The following is a description of a gene set: Human Gene Set: HP_PUBERTY_AND_GONADAL_DISORDERS species: Homo sapiens Puberty and gonadal disorders, and this is the list of marker genes: PHKG2, EIF2S3, PIGQ, POLR3GL, FLI1, ZNF365, FOXA2, PTCH1, HROB, NTN1, HLA-DQB1, SOX10, GLI3, ATRX, TAF4, STUB1, ALDOA, TBL2, FAT4, OTX2, HSPG2, SLC12A5, LHX4, DISP1, ANTXR1, GJB2, MT-ATP8 (NCBI Gene Id 4509), POF1B (NCBI Gene Id 79983), NONO, CDKN1C, POR, LPIN2, ERCC5, HESX1, GTF2IRD2, OCA2, MAD2L2, EP300, CUL4B, TXNRD2, FGF8, AGPAT2 (NCBI Gene Id 681), TGIF1, PREPL, TP53, CEP290, ATP5F1D, DUSP6 (NCBI Gene Id 1848), STAT1, NUP107, KCNT1, COL25A1, TONSL, CAMKMT, TMEM270, TSC1, PWAR1, HJV, MYT1L, DNAJC30, PDGFB, IFT74, CREBBP, SMARCE1, TGFB1, BNC1, YARS2, HBB, SNORD115-1, ROBO1, BBIP1, CNTNAP2, POLR3B, FEZF1, TFR2, SNORD116-1, MRPS22, SRCAP, PNKP, CAV1, TRAF7, ALMS1, KDM6A (lysine demethylase 6A), SCARB2, HAMP, BAZ1B, CYP17A1, USP9X, MT-TS2, PIGP, CBX2, TUBA1A, GPR101, LRP5, NFIX, GBA1, GNRHR, OPA1, TNFSF4, FKBP6, FMR1, STIL, LIG3, ZMPSTE24, TNRC6B, PPM1B, BRIP1, HS6ST1, BTK, ATPAF2, GLI2, REV3L, FSHB (follicle stimulating hormone subunit beta), GRB10, DLK1, SAMD9, NIPBL, BBS4, SMAD4, CDON, LAS1L, CFAP418, PIK3CA, STS, SCAPER, ZEB2, NEUROD2, NPHP1, XPA, EIF2B1, LSS, MMP2, PPP1R15B, SNRPN, CCDC141, SLC32A1, POLD1, DYRK1A, FANCC, SGPL1, PRKAR1A, WDPCP, POLR3K, FGD1, MAP2K1, ATP5MK, CEP19, TBC1D24, RAB18, MC2R, PEX6, SLC12A3, MKS1, SEMA3A, SRA1, LEP, SRY, VPS13B, UBE2T, NHLH2, SCN1A, DDB2, BRCA1, CASZ1, RERE, GNAS, SMO, ATP5F1A, LGR4, MT-TQ, MT-TL1, PRDM13, UBE4B, BMP4, ERCC6, FGFRL1, PHKA2, STAR, TRIP4, NNT, IL17RD, GTF2I, RBM28, LUZP1, TSC2, ALG1, CYP11B1, SOS1, DCHS1, MEN1, NDNF, IQSEC2, TRAF3IP1, MLXIPL, PMM2, HSD11B1, MMP14, BUD23, POMC, NOTCH2, ERCC8, NR0B1, PRORP, MKRN3, NPAP1, PHF21A, MAB21L2, SOX2, FOS, HNRNPR, CTNNB1, SLC39A4, GRM7, LHX3, CYP19A1, AHSG, PDE11A, SLC30A7, RIT1, DMRT1, GRIN1, TYMP, STEAP3, SPRED2 (NCBI Gene Id 200734), WWOX, NSD2, DHH, ARSL, SUFU, ENTPD1, COQ2, PYGL, GABRD, ATAD3A, IFT172, ARX (NCBI Gene Id 619216), CHD7, HCRT, PDE4D, RAB3GAP2, ELN, TERT, DLL1, SALL1, PEX1, ALG6, KMT2C, RFC2, CTDP1, ITGB6, CAVIN1, VAMP7, ITPR1, TP63, MT-TW, TUBB3, CTNS, MT-ND5, SPIDR, PTCH2, CCDC28B, PTPN11, SPTBN1, PMFBP1, HRAS, AIP, SKI, GALK1, MT-ND4, SDCCAG8, VPS4A, NRAS, BBS7, HFE, FANCF, MKKS, POLG, DEAF1, EHMT1, FOXH1, HSD3B2, PUS1, STAT5B, SLC25A13, KCNAB2, KCNA1, RECQL4, AIRE, ERCC1, MIA3, MAP3K7, BBS2 (NCBI Gene Id 583), LMNA, NCF1, STAT3, TBX3 (NCBI Gene Id 91834), BBS12, DNAL4, CLCNKB, SLC29A3, BMP6, GHR, LZTFL1, PIGA, POLR1C, TACR3, PLCB1, ZBTB20, BBS1, H4C5, VPS37D (VPS37D subunit of ESCRT-I), ARL6, FAM111B, NECTIN1, CNBP, KISS1, BRD4 (bromodomain containing 4), TUBB2B (NCBI Gene Id 347733), NSMF, DMPK, HLA-DQA1, FLII, LEPR, PIGT, CYP21A2, WRN, USP7, ESR1, SIX3, TBC1D20, MAP3K1, STX1A, MAGEL2, IER3IP1 (immediate early response 3 interacting protein 1), CBL, RAD51, RRAS2, DDX3X, IGFALS, TAF6, FREM1, MT-ND1, DHCR7, BBS5, PCSK1, MT-TF, CDH23, CRIPTO, BMP2, BBS9, NR5A1 (nuclear receptor subfamily 5 group A member 1), CISD2 (NCBI Gene Id 56831), CHRNG (NCBI Gene Id 1146), FANCI, GALT, PPARG, SCN1B, MMP1, MDM2, ZFX, PIGF, RAD21, DACT1, BMPR1B, MRE11, ZSWIM7, CPE, GAS1, RIN2, PRDM16, RFWD3, KMT2D, HACE1, ANAPC1, KISS1R, RTL1, BMP15, XRCC4 (NCBI Gene Id 7518), RRAS, SOX11, ANOS1, PLXND1 (NCBI Gene Id 23652), NF2, LHCGR, CLIP2, HDAC8, SPRTN, PTDSS1, POLE, XRCC2, NLRP3, CENPT, CARS1, FLRT3, ERCC2 (NCBI Gene Id 7269), GPR161, MECP2 (methyl-CpG binding protein 2), TAF13, MSMO1, ATM, ALX4, IFNG, CYB5A, H6PD, RAI1, MT-ATP6, GATA4 (NCBI Gene Id 2626), NDN, FANCE, MT-TH, ATP5F1E, RAD51C, BAP1, CHD4, FOXL2, IFT27, TANGO2, SLC35A2, SIL1, RAB3GAP1, PSMC3IP, BRCC3, HLA-DRB1, RPL10, RASA2, RAF1, BRAF, EIF4H, SHH, SLC25A22, NSMCE2 (NSE2 (MMS21) homolog, SMC5-SMC6 complex SUMO ligase), FANCD2, SIK1, MEG3, SPRY4, PALB2, CTSH, METTL27, AR, KMT2B, CDKL5, PLAAT3, SIX6, GTF2IRD1, FANCL, WFS1, PWRN1, TRIM8, WDR11, LZTR1, ABCD1, HERC2, SOX9, GHSR, KIF21A (NCBI Gene Id 80819), MGME1, P2RY11, MSL3, MYH3, DCAF17, ASXL3, PRKCZ, SOS2, PLAGL1, BCS1L, FANCM, SLC3A1, PRLR, TCF12, STK11, NR3C1, TWNK, BSCL2, PROKR2 (prokineticin receptor 2), MRPS7, MT-ND6, BBS10, SNAP29, FSHR, SMPD1, EXT2, ERCC4, POLR3A, MSH4, SEMA3E, POU1F1, NODAL, GMNN, GNRH1, DNM1L, SMARCB1, SLX4, NF1, PROP1, DHX37, DMXL2, LHB, TAC3, MMP23B, RNF216, MANF, TFE3, HYMAI, KRAS, SIM1 (SIM bHLH transcription factor 1), MRAP, PNPLA6, AMACR, CTBP1, SOX6 (NCBI Gene Id 84363), PEX10, POLR3H, AXL, SCLT1, PHOX2A, CYP11A1, CLPP, SCP2, SOX3, HSD17B3, AKT1, ZFPM2, GNAO1, POLA1, ANK1, WT1, FGF17, FANCG, ZIC2, MOG, FGFR1, RNU4ATAC, COL7A1, DIAPH1, RAB23, FANCA, SMC1A, PCNT, PHGDH (phosphoglycerate dehydrogenase), KANSL1, MRAS, PROK2, MAMLD1, PAPSS2, SMC3, DCC, G6PC1, SMCHD1, LETM1, BRCA2, GRIA1, RRM2B, SCN2A, SOX5, SUN5, LIMK1, INSR, ALK (NCBI Gene Id 238), SPEN, SQSTM1 (sequestosome 1), TRIM32, TRMT10A, CASK, SLC37A4, NDP, ERCC3, KCNQ2, CPLX1 (NCBI Gene Id 10815), OCRL, PTRH2, GLA, PGM1, IGF1, ZNF526, PHF6, FANCB (NCBI Gene Id 2187), MT-CO2, MT-CO1, PDPN, EIF5A, TTC8, MT-CO3, XPC